The following is a description of a gene set: Human Gene Set: GOBP_T_CELL_DIFFERENTIATION_IN_THYMUS species: Homo sapiens The process in which a precursor cell type acquires the specialized features of a T cell via a differentiation pathway dependent upon transit through the thymus., and this is the list of marker genes: ZFP36L1, STAT5A, IHH, CLEC4G, JMJD6, RIPK2, WNT1, PRR7, ZC3H8, CD74, CLPTM1, ZAP70, TP53, LIG4, BCL2, RABL3, NKAP (NFKB activating protein), CD3E, FOXN1, SOS2, PSMB11, CCR6, CTNNB1, IL7R, MAFB, FZD5, VNN1, ABL1, CCR7, TMEM131L, ADA, ATG5, JAG2, FZD7, PRKDC, RASGRP1, PTPRC (protein tyrosine phosphatase receptor type C), TNFRSF9, IL1B, SRF, ZEB1, NCAPH2, TOX, SHH, SPN (sialophorin), DOCK2, FOXP3, CAMK4, CD28, B2M, SOS1, GLI3, CARD11, ZBTB1, ADAM8, ITPKB, GBA1, IL1A, MR1, CD3D, GATA3, RIPK3, STK11, RAG2 (recombination activating 2), FZD8 (frizzled class receptor 8), CD3G, EGR3, CDKN2A, DNAJA3, FOXJ1, BCL11B, IL2RG, NFATC3, ERBB2, PTPN2 (protein tyrosine phosphatase non-receptor type 2), RAG1, TESPA1, BRAF, STAT5B, BMP4, ADAM17 (NCBI Gene Id 6868), WNT4, ZFP36L2, SOD1, AIRE, GLI2, BMI1, CDK6, FADD